Given this list of marker genes PTPN13, MAPK8, RGS3, RAC1, SRC, CXCR4, FGG, ITGA2B, EFNB1, FGB, LCK, MAP2K4, FGR, PIK3R1, YES1, TIAM1, MAP3K7, EFNB2, PIK3CA, EPHB4, EPHB2, BLK, FGA, DNM1, LYN, FYN, NCK2, HCK, ITGB3, EPHB1, here is a description of the gene set: species: Homo sapiens from publication Schaefer CF, Anthony K, Krupa S, Buchoff J, Day M, Hannay T, Buetow KH (PMID 18832364) Human Gene Set: PID_EPHRINB_REV_PATHWAY Ephrin B reverse signaling